The following is a description of a gene set: Genes up-regulated in comparison of resting regulatory T cell (Treg) versus non-suppressive T cells. species: Homo sapiens from publication Miyara M, Yoshioka Y, Kitoh A, Shima T, Wing K, Niwa A, Parizot C, Taflin C, Heike T, Valeyre D, Mathian A, Nakahata T, Yamaguchi T, Nomura T, Ono M, Amoura Z, Gorochov G, Sakaguchi S (PMID 19464196) Human Gene Set: GSE15659_RESTING_TREG_VS_NONSUPPRESSIVE_TCELL_UP Gene expression profiles of subsets of CD4+ T cells according to their expression of FoxP3 and CD45RA were compared. FoxP3 is a key transcription factor for the development and function of natural CD4+ regulatory T cells (Tregs). Here we show that human FoxP3+CD4+ T cells are composed of three phenotypically and functionally distinct subpopulations: CD45RA+FoxP3low resting Tregs (rTregs) and CD45RA-FoxP3high activated Tregs (aTregs), both of which are suppressive in vitro, and cytokine-secreting CD45RA-FoxP3low non-suppressive T cells. The proportion of the three subpopulations characteristically altered in cord blood, aged individuals, and patients with immunological diseases. Terminally differentiated aTregs rapidly die while rTregs proliferate and convert into aTregs in vitro and in vivo as shown by the transfer of rTregs into NOD-scid-common gamma-chain-knockout mice and by TCR sequence-based T cell clonotype tracing in peripheral blood of normal individuals. Taken together, the dissection of FoxP3+ cells into subsets enables one to analyze Treg differentiation dynamics and interactions in normal and disease states, and to control immune responses through manipulating particular FoxP3+ subpopulations., and this is the list of marker genes: CFAP45 (cilia and flagella associated protein 45), BEND4, ADAMTSL1, TOGARAM1, CDC26, MCUB, CD8B, CEACAM1, CFAP298, AAMP, DLX1, ASB12, DDX18, ARHGAP5, ARL4A, TEX38, CCDC88C, ATP6AP1 (NCBI Gene Id 537), CD3E, BCL2L14 (BCL2 like 14), INHBE (NCBI Gene Id 83729), FAM181B, MVB12B, ENPP3, DCAKD (NCBI Gene Id 79877), ASB4, CHL1, C9orf40, ASCL3, ARSL, CD46, LINC00951 (NCBI Gene Id 401260), CA5BP1, FOSL2-AS1, CNGA3, EML3, CHCT1, CST11, FAM86C1P, CDK5RAP2, CACNA1G, FAM47A, SCP2D1, FBRSL1, CCDC15, TMEM263, INTS6L, CSNK1G3, CA8 (NCBI Gene Id 767), SIGLECL1, AP4B1, C10orf53, CBY3, ATM, BLCAP, C3orf70, FKBP7, FAP, ARPIN, COPG2, CHRNA1, CCDC152, SPOUT1, CCDC115, CHRM5, ALK, ABT1, ADAMTS5, DLL3, DNAJA4, ACAT2, EIF3K, DLGAP1-AS1, DUS4L, COBL, ENTPD3, CHPF, FBXL14, PIEZO2, CGGBP1, ARHGEF16, ENTPD2, FAM111B, ATAD3A, CSNK1D, CELF6, COL6A6, ATRN (NCBI Gene Id 8455), C3orf85, ERP29, CES1, EME1, LINC01588 (long intergenic non-protein coding RNA 1588), FLYWCH2, CALCA, CHRNG, CDHR5 (NCBI Gene Id 55618), CLTCL1, SUCO, ANAPC15, ATXN1L, AGXT, CABLES1, EPHX3, DUS1L, ZNF736, BOLA1, DOHH, CHRNB1, BPIFB6, LINC02210, ATXN3L (NCBI Gene Id 92552), CTSV, LINC02915, ECI2, EOMES, CTAG2, CCDC28B, SOWAHA, CCS, PAGR1, COIL, PRR29, CXCL2, CPLX2, SCN8A, EP400P1, DAD1, CAMK1D, AGRN, TRMT13, MPV17L, CYTH2 (NCBI Gene Id 9266), C1R, CYMP, OGFOD3, DEPTOR, CNPY1, ZGRF1, CSPG5, CHKA, ETS1, ARIH1, CARD10, CPNE6, DHX58, CEACAM19, DNAAF10, CGNL1, ALOX12, ENPP7, TBATA, ERCC8, BBS1, C20orf202, FBXL16, CLCN3, SLC25A3P1, COG1, CNTFR, BCOR, DNAH17, CNOT4, BBOX1, ATP6V0C, ASF1A, ALX4 (ALX homeobox 4), CACNG7, FBXO46, CSH1, ZNF436-AS1, CHCHD7, BTAF1, AMER1, AMER2, DMBX1, CD7, CST8, EMID1 (NCBI Gene Id 129080), LINC00587, EPM2AIP1, EEF1D, ALKBH7, AMPH, EFNB1 (NCBI Gene Id 1947), CHRNA2, EMILIN3, BCL11A, ALX1, DPYS, CCDC180, C2orf15, CDH15, CPNE3, C1QTNF7